Given this list of marker genes C1qb, Igkv1-122, Ighv5-9-1, Ighv6-5, Ighv8-13, Ighv3-4, Iglc2, Igkv1-131, Igkv1-133, Ighv5-4, Ighv7-2, Igkv18-36, Ighv8-6, Igkv1-88, Ighv8-8, Ighv8-9, Igkv1-117, Igkv1-35, Ighv5-17, Ighv3-5, Ighv8-12, Igkv20-101-2, Ighv8-4, Iglc1, Ighv13-2, Igkv1-132, Ighv5-9, Igkv2-137 (NCBI Gene Id 692187), Ighv3-1, Igkv1-99, Ighg1, Ighg2c, C1qc, Igkv17-121, Igkv8-21, Ighg3, Ighv3-3, C1s2, Igkv2-112, Ighv8-5, Ighv16-1, Crp, Ighv3-6, Ighv7-4, Ighv5-12-4, Igkv11-125, Ighv12-3, Ighv5-15, Igkv15-103, Igll1 (immunoglobulin lambda-like polypeptide 1), Ighv6-4, Ighv6-6, Igkv1-135, Ighv5-12, C1ra, Igkv1-110, Ighv7-3, Ighv6-3 (immunoglobulin heavy variable 6-3), Ighv8-11 (NCBI Gene Id 636462), Ighv5-6, C1qa (NCBI Gene Id 12259), Igkv16-104, Igkv2-109, Ighv8-2, Ighv5-2, Ighv3-8, Ighv6-7, Ighv5-16, here is a description of the gene set: species: Mus musculus Mouse Gene Set: REACTOME_CLASSICAL_ANTIBODY_MEDIATED_COMPLEMENT_ACTIVATION Classical antibody-mediated complement activation